Given this list of marker genes ELANE, TLR8, SF3B1, AK2, RPS28, TAFAZZIN, UNC13D, TET2, here is a description of the gene set: Human Gene Set: HP_DECREASED_TOTAL_GRANULOCYTE_COUNT Abnormal decrease of absolute number of granulocytes in the blood, per microliter, compared to a reference range for a given sex and age-group. studied in species Homo sapiens Decreased total granulocyte count